Given this list of marker genes POLA1, RFC5, ATR, ALKBH2, SEM1 (SEM1 26S proteasome subunit), UBE2N, TOPBP1, MRE11P1, RRM2, TEP1, UBE2A, GADD45A, MAD1L1, CSNK1D, BRCA1, MRE11, UBA1, TOP2A, HMGB1, POLB (DNA polymerase beta), RAD51AP1, ERCC5, RBBP8, SMC3, RRM1, BRIP1, TERF1, UBE2L3, TOP3A, POLK, WRN, MSH5, DDB2, GADD45G, TP73, WRNIP1, NEIL1, RAD51C, MLH3, ATRX, POLQ, SMC2, GTF2H5, UBE2B, CCNH, PTTG1, RAD21, CRY1, ERCC1, HMGB2, TP53BP1, POLH, TREX2, N4BP2, RAD17, APEX1, TP63, RECQL5, MSH6, FANCD2, CHEK1, RAD50, UNG, ENDOV, XRCC1, XRCC3, PMS2P2 (PMS1 homolog 2, mismatch repair system component pseudogene 2), MBD5, ERCC3, PNKP, RAD54L, DCLRE1A, H2AX, DCLRE1B, ERCC6, POLL, POLI (NCBI Gene Id 11201), CDK7, MPG (NCBI Gene Id 4350), EXO1, NTHL1, TERT, TP53I3, PMS2, SMC4, SMC1A, TINF2, MLH1, POLM, MTOR, SSRP1, XRCC6, ABL1, TOP3B, XAB2, RPA4, NUDT3, LIG3, CHAF1A, BRCA2, FANCB, SUPT16H, RFC1, PRKDC, TOP2B, CHEK2, HUS1, NEIL2, RAD9B, DCLRE1C, UBE2D3, MSH4, ERCC8, UBE2V2, PARP1, TENT4A, MBD3, EME1, ERCC2, PCNA, MAD2L2, GTF2H2 (NCBI Gene Id 2966), RAD52, RDM1, APEX2 (apurinic/apyrimidinic endodeoxyribonuclease 2), RFC3, POLG, MGMT, RAD1, ALKBH1, TDP1, POLG2, MSH2, MMS19, SUMO1, RPA3, XRCC2, POLE, POLD4, POLE3, MNAT1, CETN3, XRCC5, RAD23A, RUVBL2, RPA2, RAD23B (RAD23 homolog B, nucleotide excision repair protein), XRCC4, CHAF1B, FEN1, NBN, DMC1, CDKN1A, MUS81, ERCC4, POLE2, PARP4, RAD9A, POLD3, FANCL, NUDT1, GTF2H3, POLE4, SMUG1, LIG4, DUT, ATM, RAD51B, RFC2, CSNK1E, RPA1 (NCBI Gene Id 6117), PMS1, MUTYH, FANCA, REV1, TOP1, POLN, MBD1, UBE2D2, XPA, BLM, MSH3, CRY2, ATP23, RAD51, GTF2H1, TERF2, PMS2P4, FANCE, FANCG, CIB1, PMS2P1, XPC, NEIL3, ALKBH3, SPO11, DDB1, CETN2, WDR33, PMS2P5, FANCC, FANCF, OGG1, RAD18, REV3L, RFC4, TDG, POLD2, RAD51D, MBD2, PMS2P3, POLA2, UBE2I, MAD2L1, RIF1, POLD1, PARP3, LIG1, TP53, RBBP4, RRM2B, SMC1B, RAD54B, RECQL4, APTX, MBD4, FANCM, GTF2H4, PARP2, TREX1, here is a description of the gene set: We have identified a gene-profile signature for human primary malignant melanoma associated with metastasis to distant sites and poor prognosis. We analyse the differential gene expression by looking at whole biological pathways rather than individual genes. Among the most significant pathways associated with progression to metastasis, we found the DNA replication (P=10(-14)) and the DNA repair pathways (P=10(-16)). We concentrated our analysis on DNA repair and found that genes of this category, among a list of genes, are associated with metastatic progression. These genes belong essentially to the pathways allowing recovery of stalled replication forks due to spontaneous blockage or induced DNA lesions. Because almost all these differentially expressed repair genes were overexpressed in primary tumors with bad prognosis, we speculate that primary melanoma cells that will metastasize try to replicate in a fast and error-free mode. In contrast to the progression from melanocytes to primary melanoma, genetic stability appears to be necessary for a melanoma cell to give rise to distant metastasis. This overexpression of repair genes explains nicely the extraordinary resistance of metastatic melanoma to chemo- and radio-therapy. Our results may open a new avenue for the discovery of drugs active on human metastatic melanoma. Genes involved in DNA repair, compiled manually by the authors. from publication Kauffmann A, Rosselli F, Lazar V, Winnepenninckx V, Mansuet-Lupo A, Dessen P, van den Oord JJ, Spatz A, Sarasin A (PMID 17891185) Human Gene Set: KAUFFMANN_DNA_REPAIR_GENES species: Homo sapiens